The following is a description of a gene set: species: Homo sapiens Neighborhood of FDXR Neighborhood of FDXR ferredoxin reductase in the MORF expression compendium Human Gene Set: MORF_FDXR, and this is the list of marker genes: TBX1, NUDT3, ITIH4, PIGR, CSTF3, PARN, PAX9, WDR62, TCOF1, LTBP4, GRK4, F7, SLC12A4, PARVB, CLP1, IRF2BP1, NELFB, PIGB, LSM12, HOXD4, IKBKE, TBCD, RASSF1, SLC5A2, DOK1, CYP4F12, TUBGCP4, CHD3 (chromodomain helicase DNA binding protein 3), SSTR5, HSF4 (NCBI Gene Id 3299), CDK5R1, KLHL18, BAHD1, SLC6A7, RCE1, SLC24A1, MFN2, WNT10B, CNP, PRSS16, DAPK2, AQP5, NFIC, KANK2, EFNA2, CLOCK, PIK3CB, GALNT2, PRELID3A (NCBI Gene Id 10650), TCF7, ADAMTSL2, RBBP8, ATRX, AGPAT1, ITPR2, KRT33A, HSPB2, SLC16A5, SIX3, HMG20B, DGCR11, CSNK2A1, PML, AMFR, SLC4A3, CMA1, CYP11A1, DHRS1, TUBGCP2, SH2B1, CAMK2B, JAG1, HAUS5, B4GALT3, ZNF500, PAXIP1, GSK3B, SPEF1, CRYAA, WWOX, SIK3, PPIL2, SFSWAP, MSX1, FKBP15, RPS6KB2, RERE, SLC30A1, MYC, TMEM94, GRIP2, ACKR2, CD6, PAIP2B, JRK, MTX1, EIF5B, CALCOCO1, SLC30A3, HTR4, SLC13A2, COLQ, CNTN2, LMO1, KLHDC10, CAMK2G, CLPX (NCBI Gene Id 10845), ECE2, MYO9B, ZNF592, USP19, NDST1, NCKIPSD, RTN2, TM4SF5 (NCBI Gene Id 9032), KRT86, IGHMBP2 (immunoglobulin mu DNA binding protein 2), JAK3, MOK, GTF2H3, ILVBL, DIP2C, ERCC2, KAT8 (NCBI Gene Id 88034), SLC2A1, PITPNM1, AP2A2, TBX5, MUTYH (mutY DNA glycosylase), CYP19A1, DPT, DKK4, PAX8 (paired box 8), DDX11, NFYB (NCBI Gene Id 4801, nuclear transcription factor Y subunit beta), SETD1B, MC2R, SDC3, TNP1, CHRND, BTD, LTK, LDB1, PTPN9, PRKCSH, LSM1, TTI1, TBC1D22A, PCGF1, MR1, CBARP, NFRKB, BPHL, PCBP3, EML3 (EMAP like 3), PLEKHB1, CD8B, PHB1, CRHR2, TPR, LINC00928, TAF2, FUT6, SLC6A9, ENTREP1, PPP1R10, IPCEF1, ENTREP3, LBP, TMEM11, IRF2, ELK1, RANBP2, CASP2, FRYL, PMF1, AP3B1, FANCG, TLN2, EXTL3, MPP2 (NCBI Gene Id 4355), DDX51, CPSF4, RFC5, ANKRD12, IKBKG, HTR7, GLE1, TNFRSF25, MT4, MLN, KIFC3, CARD10, BCL2, CDK13, ABHD14A, RPA2, CRYBA4 (NCBI Gene Id 1413), SPTB, MUSK, ZKSCAN3, PVT1, KHNYN, DDB1, RABGGTA, ARSL, SLC22A24, HNRNPL, IMPA1, TRIM27, MGAT1, SULT1A1, IGSF9B, CRCP (CGRP receptor component), KYAT1, CEP135, ADAM15, ERAL1, FDXR, SLC25A11, GRIK5, PPP5C, ALDOC, GPR35, PKMYT1 (NCBI Gene Id 9088), RBM8A